The following is a description of a gene set: from publication Marigo I, Bosio E, Solito S, Mesa C, Fernandez A, Dolcetti L, Ugel S, Sonda N, Bicciato S, Falisi E, Calabrese F, Basso G, Zanovello P, Cozzi E, Mandruzzato S, Bronte V (PMID 20605485) Genes up-regulated in CD11b+ cells from spleen of BALB/c mice bearing C26GM colon carcinoma versus CD11b+ cells from bone marrow of healthy BALB/c mice. studied in species Homo sapiens Tumor growth is associated with a profound alteration of myelopoiesis, leading to recruitment of immunosuppressive cells known as myeloid-derived suppressor cells (MDSCs). Analyzing the cytokines affecting myelo-monocytic differentiation produced by various experimental tumors, we found that GM-CSF, G-CSF, and IL-6 allowed a rapid generation of MDSCs from precursors present in mouse and human bone marrow (BM). BM-MDSCs induced by GM-CSF+IL-6 possessed the highest tolerogenic activity, as revealed by the ability to impair the priming of IFN- -producing CD8+ T cells upon in vivo adoptive transfer. Moreover, adoptive transfer of syngeneic, GM-CSF+IL-6-conditioned MDSCs to diabetic mice transplanted with allogeneic pancreatic islets resulted in long term acceptance of the allograft and correction of the diabetic status. Cytokines inducing MDSCs acted on a common molecular pathway. Immunoregulatory activity of both tumor-induced and BM-derived MDSCs was entirely dependent on C/EBP transcription factor, a key component of the emergency myelopoiesis triggered by stress and inflammation. Adoptive transfer of tumor antigen-specific CD8+ T lymphocytes resulted in therapy of established tumors only in mice lacking C/EBP in myeloid compartment. These data unveil another link between inflammation and cancer and identify a novel molecular target to control tumor-induced immune suppression. We used gene expression analysis to identify those factors, secreted by tumor-infiltrating MDSC, which could drive emathopoiesis. Moreover we compare gene expression profile of tumor-induced MDSC, obtained from either the spleen and the tumor infiltrate of tumor bearing mice, and in vitro bone marrow-derived MDSC. Human Gene Set: GSE21927_SPLENIC_C26GM_TUMOROUS_VS_BONE_MARROW_MONOCYTES_UP, and this is the list of marker genes: SERINC5, ETV6, MRPL24, CHL1-AS2, SLC22A9, HIPK2, DLEU7 (deleted in lymphocytic leukemia 7), SEMG1, USP6NL, LSMEM2, CCL22, FGF1, RAB3D, ADGB, PPARG, ACTL9, GLI1, NPPB, PTCRA, PBXIP1, ARL8B, MMP2, AGR2, CPB2, KANSL1L, AGT, PAGE4 (PAGE family member 4), ANKRA2, AK5, CCDC125, PDS5B, LACTB2, NPEPL1, HRC, FLNC, MRPL44, TMEM106A, SNX27, MYL9, BMP15, COL16A1, DDAH1, GPR39, YTHDC2, DCAF7, DGCR5, NBEAP1, LINC01550, RNF103, TUT7, HNRNPD, PRDM6, PPARGC1A, KLHL34, MYL3, TAFA1, GUCY1B1, ENSG00000237250, GCNT4, CATSPERD, AMOTL1, KCNJ10, BHLHE22, ZNF705G, SEMA3B, KCNK4, PSMB5, BMX, IGSF22, UST-AS1, KISS1, RNASE2, DENND11 (DENN domain containing 11), MT1HL1, INSIG1, TOM1L2, CFAP74, TMEM277P, TAB1, HYCC2, BTNL9, SNED1, PIP, EEF1A1, NUMB, HIGD1A, NEURL3, FILIP1L, MAPK10, ZBED3-AS1, OGFRL1, CLCN3, AREG (amphiregulin), ARSB, MIR1915HG, NOD2, CYREN, SCAMP5, CXCL9, SYN3, C12orf42, USP48 (ubiquitin specific peptidase 48), RBL1, TRPS1, TMPRSS3, WNK4, KRT31, GPHA2, STT3B, LRIT1, ADARB2, PCDHB3, SAMD3, OGA, MAGEE1, PRKCZ-AS1, FAXDC2, PHF3, TRIM39, TREM2, HSPH1, ENSG00000229727, ENSG00000291179, PDX1, CDK11A, FBXO8, NF1, SLN, MAK, CLCF1, ANKRD40CL, LINC00607, PHC3, FOXN3-AS2, WWC2-AS2, PLEKHG3, FANCD2OS, KRT2, RAB5C, CDC42EP5, CIMIP5, ZBTB7C-AS2, CAPN12, FRMD1, PANK3, LINC02145, RASD2, EBLN3P, CCDC61, IFNA7 (NCBI Gene Id 3444), ENSG00000255647, NDUFV1-DT, CACNA2D1, APBB1, COL11A2, FAM30A (NCBI Gene Id 9834), CYP4B1, TUB, GABRA1, KIR3DS1, MMP17, MIR22HG, RIIAD1, BEX4, SLC22A4, ELSPBP1, CEBPA-DT, HTRA3, UGT2B28, VPREB1, CMAHP, CCDC134, LRRC37A5P, LINC00324, CDC42EP2, TBKBP1, TMSB15B-AS1, PCNA, UNC13C, LINC00052, KRT7, NCDN, RGS9 (NCBI Gene Id 8787), SART3